The following is a description of a gene set: Mouse Gene Set: GOBP_PURINE_DEOXYRIBONUCLEOTIDE_METABOLIC_PROCESS studied in species Mus musculus The chemical reactions and pathways involving purine deoxyribonucleotide, a compound consisting of deoxyribonucleoside (a purine base linked to a deoxyribose sugar) esterified with a phosphate group at either the 3' or 5'-hydroxyl group of the sugar., and this is the list of marker genes: Nudt15, Uox, Gda, Dnph1, Ak2, Urad, Nt5c2, Nudt16, Urah, Ada, Adk, Dguok, Xdh, Oga, Pnp, Nt5c, Guk1, Nt5c1a, Ak3, Nudt18, Samhd1, Dck